Given this list of marker genes ZNF217-AS1, GP1BA, ADAMTSL4-AS2, PRELID2, DAAM1, IPCEF1, BIRC7 (NCBI Gene Id 79444), NRGN, CBFA2T3, TAL1, PSTPIP2, LIMS1, H2BC4, STXBP5, TLN1, P2RX1, MCU, HNRNPLL, LINC00989, ANKRD40, LRRC14, PDCD10, C11orf21, MOB3C, LEFTY1, SAMD14, ENSG00000255240, TBXAS1 (thromboxane A synthase 1), FHOD1, ZNF431, ACRBP, EHD3, PRKAR2B, KCNT2, RAB30-DT, SELP, ANKRD33B, NEXN, C20orf203 (NCBI Gene Id 284805), MYLK-AS1, ARHGAP6, XYLT2, MBOAT2, MDM1, PRUNE1, CNST, BCL2L1, SAV1, FN3K, BANK1, TUBB1, CAVIN2, MINDY1, EXOC3L4, RHAG, GABRB1, ITGA9-AS1, ATP2C1, MAX, RASA3, RGS18, RPS14P4, MYO3B, MARCHF2, DBN1, PYCR2, EFHC2 (EF-hand domain containing 2), PLEKHA8P1, CHEK1, SEC31B, MYT1L, XRCC2, HABP4, PF4, NT5M, MIEF2, PRKCB, PROSER2, TMEM91, RELCH, LMO2, LGALSL, PRTFDC1, RAB27B, PPBP, GP6, MIGA2, C1QTNF12, CD226, PKHD1L1, INHBA-AS1, DNM3, OSBP2, CENPL, DNM1P47, BIN2, RAB3C, TEX22, LINC02284, VEPH1, KIF9, ENSG00000227355 (novel transcript, antisense STOM), LINC00667, PLA2G12A (phospholipase A2 group XIIA), EGF, ZNF561-AS1, NOL9, TSPAN32, MYOM1, C20orf96, COL24A1, THBS1, MAVS, RGS6, XIRP2, RNU6-299P, RN7SL801P, ANGPT1, RFXAP, OR2W3, RIPOR3, ILK, TRIM58, MLC1, LRRC8B, CENPT, PTGS1, LIMASI, LINC00534, FOXP1-IT1, INKA1, DAPP1, LRP12, TSPAN33, TNIK, ZBED4, EFCAB13-DT, TGFB1, PEAR1, DCLRE1A, ZMYND8, LINC02604, HTR2A, NQO1, KATNAL1, DYNC1I1, TSPOAP1-AS1, TBC1D20, ACTR3B, STON2, PRKAR2B-AS1 (PRKAR2B antisense RNA 1), RN7SL452P, MFSD2B, SLC7A11, H2AC6, NLK, ITGB3, CRACD, MPIG6B, ATP1A1-AS1, DENND2C, SLC8A3, ITGA2B, GAS8, RNF24, ANK1, KIAA0513, MKRN2, SOCS3-DT, MCTP1, KDM7A-DT, ZNF346, RAB37, TUBA4A, RNU6-272P, EPHA10, MMRN1, RNF215, MYO18B, NT5C3A, TMEM40, RFFL, VPS11, WNT7B, F2RL3, ABCC4, ZFPM1, ARMC3, DNAJB2, RBM38, DGKG (diacylglycerol kinase gamma), ENSG00000230773, CDC14B, TMEM74, RUFY1, VCL, CPA6, RAP1B, LINC01089, FERMT3, SNCA, CAVIN2-AS1, PTGIR, GRK5-IT1, here is a description of the gene set: The gene expression program underlying the specification of human cell types is of fundamental interest. The study authors generated human cell atlases of gene expression and chromatin accessibility in fetal tissues. For gene expression, the study authors applied three-level combinatorial indexing to >110 samples representing 15 organs, ultimately profiling ~4 million single cells. The study authors leveraged the literature and other atlases to identify and annotate hundreds of cell types and subtypes, both within and across tissues. Our analyses focused on organ-specific specializations of broadly distributed cell types (such as blood, endothelial, and epithelial), sites of fetal erythropoiesis (which notably included the adrenal gland), and integration with mouse developmental atlases (such as conserved specification of blood cells). These data represent a rich resource for the exploration of in vivo human gene expression in diverse tissues and cell types. Marker genes curated from the annotated cluster as represented in the Descartes Human Gene Expression During Development database. Human Gene Set: DESCARTES_FETAL_PLACENTA_MEGAKARYOCYTES studied in species Homo sapiens from publication Cao J, O'Day DR, Pliner HA, Kingsley PD, Deng M, Daza RM, Zager MA, Aldinger KA, Blecher-Gonen R, Zhang F, Spielmann M, Palis J, Doherty D, Steemers FJ, Glass IA, Trapnell C, Shendure J (PMID 33184181)